Given this list of marker genes IDH3A, RGR, AHR, SLC6A6, RP2, PEX26, CRB1, CA4, RDH5, USH2A (NCBI Gene Id 7399), PRCD (photoreceptor disc component), SNRNP200, RPGR, RRM2B, IMPG2, PEX2, DHX38, ALMS1, PEX10, CDHR1, RLBP1, DNM1L, PEX13, RPE65 (NCBI Gene Id 6121), ROM1, PRPF8, POU3F4, SDHA, NEK2, IFT140, ELOVL1, PEX16, MT-ATP6, RPGRIP1, IFT88, BBS2, DHDDS, MYOC, CHM, AMACR, RAX2, SH3BP2, OPA1, POC1B, GUCY2D, PRPF6, OAT, PCARE (photoreceptor cilium actin regulator), SCAPER, SEMA4A, RHO, SLC7A14, CRX, PROM1, LZTR1, PEX19, PRPF3 (NCBI Gene Id 9129), TMEM126A, KIAA1549, ARL6, BBS1, TOPORS, PRPH2, AGBL5, CCDC28B, PEX5, PDE6A, RP9, FAM161A, AHI1, RP1L1, PEX11B, KLHL7, CYP1B1, POMGNT1 (protein O-linked mannose N-acetylglucosaminyltransferase 1 (beta 1,2-)), CNGB1, PEX14, IDS, PEX6, AIPL1, RDH12, IDH3B, LRAT, TUB, RNU4ATAC, REEP6 (NCBI Gene Id 92840), RP1, YARS1, TULP1, DLAT, FSCN2 (fascin actin-bundling protein 2, retinal), CWC27, TTC8, TIMM8A, CACNA2D4, MERTK (MER proto-oncogene, tyrosine kinase), ARSG, AIRE, PRPF4 (NCBI Gene Id 9128), SOST, NRL, RDH11, ARL3, IFT172, NR2E3, CLRN1, SH3TC2, IMPG1, ZNF513, KIZ, MIEF1, HKDC1, SPATA7, PDE6G, PEX1, ARHGEF18, ZNF408, EYS, CFAP418, GNAT1, HGSNAT, PEX3, RBP3, MAK, GUCA1B, ARL2BP, SAG, ABCA4, PEX7, CERKL, EFEMP1, CC2D2A, LCA5, CYP4V2, IMPDH1, OFD1, BEST1, PRPF31, CNGA1, KIF3B, HK1, PEX12, PDE6B, here is a description of the gene set: species: Homo sapiens Human Gene Set: HP_CONSTRICTION_OF_PERIPHERAL_VISUAL_FIELD Constriction of peripheral visual field An absolute or relative decrease in retinal sensitivity extending from edge (periphery) of the visual field in a concentric pattern. The visual field is the area that is perceived simultaneously by a fixating eye.